The following is a description of a gene set: studied in species Homo sapiens Catalysis of the transfer of the amide nitrogen of glutamine to a substrate. Usually composed of two subunits or domains, one that first hydrolyzes glutamine, and then transfers the resulting ammonia to the second subunit (or domain), where it acts as a source of nitrogen. Human Gene Set: GOMF_CARBON_NITROGEN_LIGASE_ACTIVITY_WITH_GLUTAMINE_AS_AMIDO_N_DONOR, and this is the list of marker genes: GATC, ASNS, ASNSD1, CAD, QRSL1, GMPS, GATB, PFAS, CPS1, NADSYN1